Given this list of marker genes CALML4, MYL12B, MYL12A, MYBPC3, MYL4, MYL2, CORO1A, MYL3, STX1A, LIMCH1, NKD2, SPTBN5, MYL9, here is a description of the gene set: Binding to a heavy chain of a myosin complex. Human Gene Set: GOMF_MYOSIN_HEAVY_CHAIN_BINDING species: Homo sapiens